The following is a description of a gene set: In the present study we used Affymetrix oligonucleotide microarrays to produce gene transcription profiles for the major leukocyte types in humans. This comprehensive dataset enabled us to not only establish which genes were expressed in each leukocyte type, but also which genes were expressed in each subset after activation. The used of a comprehensive dataset of gene profiles from all the major human leukocyte subsets enabled a novel and powerful means for identification of genes associated with single leukocyte subsets, or different immune paradigms. Human Gene Set: GSE3982_BASOPHIL_VS_EFF_MEMORY_CD4_TCELL_DN Genes down-regulated in comparison of basophils versus effector memory CD4 T cells. from publication Jeffrey KL, Brummer T, Rolph MS, Liu SM, Callejas NA, Grumont RJ, Gillieron C, Mackay F, Grey S, Camps M, Rommel C, Gerondakis SD, Mackay CR (PMID 16474395) studied in species Homo sapiens, and this is the list of marker genes: TEX10, MGLL, POLR2H, SSX7, HSF1, ENSG00000290731, PHF1, CTNNAL1, ZNF473, DNAJB12 (DnaJ heat shock protein family (Hsp40) member B12), HAUS7, H2AC17, PSKH1, BAG3, SEMA3G, FZD8, ZNF202, AMPD2, THADA, PLXNC1, SZRD1, DCTPP1, GREM1, PURG, TRBC1, TRAM2, RPL14, DCUN1D4, NOLC1, ZNF446, MAVS, ELK3, NOP14-AS1, PSORS1C2, ACTR1B, PGC, FLT3LG, PFKM, GRM6, GAA, ME3, CLNS1A, DOHH, CLIP4, HMX1, SUV39H1, IPCEF1, RET, CTSC, TF, PAPPA2, TSC1, ZC3H7B, NUDCD3, CLDN6, CHMP6, SH2B1, ENDOD1, NECTIN2, PRKAR2A, LIG1, EIF3I, ITGB2, LRCH4 (leucine rich repeats and calponin homology domain containing 4), EVI2A (NCBI Gene Id 2123), WDR18, DOCK9, DNAJA4, ACOT8, RBM12B, ATG101, WIZ, SLC17A1, POLR2J2, CLCA4, BEAN1, PAM, OGFOD3 (2-oxoglutarate and iron dependent oxygenase domain containing 3), SCAND1, GZMA, TMC5, FAM200C, ACSM3, CDC37, GLB1L2, EEF2, ALOX15B, THBS3, GFOD2, HEATR3, TCERG1 (transcription elongation regulator 1), CLUH, DIP2C, GRM4, FOXO3, CBR1 (carbonyl reductase 1), MED16, APOO, GAK (cyclin G associated kinase), ITGB1, ITIH5, TDP1, SMIM7, RAB11FIP5, SLC19A1, VASH1, PRR14L, GTF2IRD1, PLEKHG6, CPN2, NUFIP1, CCNP, SLC39A8, MICAL2, VSTM4, PCDHB6, HNRNPA3, ADGRA3, DCAF11, PHC1, PARP2, NHEJ1, RRN3P1, OR2B6, VASP, PEX26, ARHGAP22, SKAP1, EIF2B3, WRNIP1, BCAP31, FASTKD2 (NCBI Gene Id 22868), HACD3, DPY19L2P2, MOCS3, FABP7, MICALL1, COL10A1, SLC4A4, CLCN5, SIRT4, KLF8, TGFBR3, BCS1L, TUBA8, CAD, CACNA1H, KRT75, RPSA, TRPV2, HDHD3, MFHAS1, ANKS1B, PYGB, CNNM1, IL10, PPM1F, SCN3A, RANGRF, PRDM12, FAT4, CAMK2B, POLD1, NR2F2, AQP1, NRBP1, SYNE1, FBXO21, ESM1, SHLD2, IL6, RPS6KA3, ZNF665 (NCBI Gene Id 79788), OR2H1, NDRG2, CD248, PMEL, SV2A, MAPKAPK5-AS1, KLF12, NCKIPSD, DIAPH2, C1QTNF1, UPF1, LINC01278, IL3, SNTG1, ATG13, SLC6A2, CEACAM4, PPP1CC, HOXC11, MTMR1, NUBP2, GRIN2D, PLA2G4C, MCUB